Given this list of marker genes ATP1A2, BCCIP, MTSS2, ACO2, KIF3B (kinesin family member 3B), SYN3, here is a description of the gene set: Genes predicted to be targets of miRBase v22 microRNA hsa-miR-127-3p in miRDB v6.0 with MirTarget v4 prediction scores > 80 (high confidence targets). species: Homo sapiens Human Gene Set: MIR127_3P from publication Chen Y, Wang X (PMID 31504780)